The following is a description of a gene set: species: Homo sapiens Human Gene Set: HP_NEUROPATHIC_SPINAL_ARTHROPATHY A progressive disorder of vertebral joint degeneration that occurs in the setting of any condition characterized by decreased afferent innervation, involving loss of deep pain and proprioceptive sensation in the vertebral column. Patients most commonly present with symptoms of lower back pain, sitting imbalance, progressive spinal deformity (usually kyphosis), and an audible clicking sound on changing postures. Neuropathic spinal arthropathy, and this is the list of marker genes: SH3TC2, SYT2, EBP, SLC25A1, COL13A1, VAMP1, EXT2, MGME1, SLC18A3 (NCBI Gene Id 6572), POMT2, GNE, SLC5A7, POMT1, LARGE1, CHAT, EXT1, AGRN (NCBI Gene Id 389836), SNAP25, SNX14, GDAP1, MYO9A, FKRP, GMPPB